Given this list of marker genes Hmgb1, Spn, Ccnd3, Gal, Slc4a2, Abl1, Cd27, Sh2d2a, Cd209d, Tnfrsf14, Nfix, Lep, Il12b, Slfn1, Itgal, Ctps1, Lgals3, F2rl1, Zfp335, Dock8, Ido1, Aif1, Foxj1, Marchf7, Armc5, Itch, Btk, Zp3, Pla2g2f, Cd300a, Lef1, Zc3h12d, Tmem131l, Tnfrsf4, Slc39a10, Cd180, Itgb2, Coro1a, Clec2i, Cd40, Impdh2, Crip3, Phf7, Icosl, Gnrh1, Irf1, Vav3, Sftpd, Havcr2, Cd59a, Cd24a, Il2 (NCBI Gene Id 16183), Cdkn1a, Cd70, Il1a, Vtcn1, H2-DMb1, Cd22, Irs2, Il7r, Bcl2l1, Ceacam1, Ifnar2, Vsig4, Vpreb1b, Enpp3, Ccr2, Ager, Dhps, Plcl2, Nmb, Arg2, Hhex, Tnfsf4, Selenok, Pnp, Tarm1, Crtam, Ocstamp, Ndfip1, Il7, Mif, Pawr, Cd209a (NCBI Gene Id 170786), Flt3l, Itgax, Csf2, Ccdc88b, Cnn2, Kctd9, Pla2g2a, Cd3e, Satb1, Erbb2 (erb-b2 receptor tyrosine kinase 2), Trem2, Ptprc (protein tyrosine phosphatase receptor type C), Il23a, Casp3, Efnb1, Tnfsf13, Hprt1, Rag2, Flt3, Cd59b, Mzb1, Gpam, Cx3cl1, Gsk3b, Znhit1, H2-Aa, Tyrobp, Cd74, Csf2ra, Stat5a, Cd44, Myd88, Lilrb4a, Ikzf3, Kitl, Il12a, Cd320, Pla2g2d, Vcam1, Dlg1, Tnfrsf21, Csf2rb, Prlr, Azi2, Pcyt1a, Fgf10, Cd38, Sos1, Ada, Adk, Traf6, Pth, Ctnnb1, Inpp5d, Cd209e, Fkbp1b, Chrnb2, Sh3rf1, Carmil2, Rc3h2, Syk (spleen tyrosine kinase), Clec4g, Nmbr, Vpreb1a, Il13, Cebpb, Rc3h1, Msn, Gpnmb (NCBI Gene Id 93695), Impdh1, Tyk2, Anxa1, Vsir, Malt1, Ihh, Ticam1, Ptk2, Pycard, Tirap, P2rx7, Tlr9, Tnfsf13b, Il27, Ahr, Npr3, Sdc4, Ifng, Jak2, Slc7a1, Il4i1, Tbk1, Tnfsf11, Tnfrsf13c, Bcl6, Gstp1, H2-DMb2, St6gal1, Pde5a, Wnt4, Rasgrp1, Bid, Clu, Fosl2 (fos-like antigen 2), Cd6, Ephb6, Clcf1, Il3 (NCBI Gene Id 16187), Prkcd, Tnfrsf9, Ripk2, Cd4, Tnfrsf13b, Sash3, Itgam, Il20rb, Nckap1l, Wnt3a (NCBI Gene Id 22416), Cd81, Nfatc2, Sos2, Prnp, Btnl2, Fadd (Fas associated via death domain, NCBI Gene Id 14082), Xcl1, Cd19 (CD19 antigen), Slc4a1 (solute carrier family 4 (anion exchanger), member 1), Lipa, Blm, Btn2a2, Il18, Nck2, Ifnb1, Tcf3, Mapk8ip1, Myc, Alkbh5, Rac2, Bmp4, Tspan32, Ripk3, Tnfsf9, Psmb10, Scrib, Stat5b, Lgals9, Pura, Cd244a, Hspd1, Il2ra, Il5, Elf4, Il6, Lyn, Ighm, Mapk1, Dnaja3, Emp2, Ighd, Tnfsf18, Rps6, Cdkn2a, Csf1r, Cfb, Fkbp1a, Lilrb4b, Il1b, Pkn1, Cd151, Igf2, Bap1, Prdx2, Ccl12, Spta1, Scgb1a1, Cblb, Zbtb7b, H2-M3, Zap70, Cd46, Il4, Bmi1, Cd55, Cd79a, Igf1, Muc19, Cd209c, Cxcl12, Il34, Ccr7, Glmn, Siglecg, Laptm5, Ndp, Fcgr2b, Cd37, Cd274, Nr5a2, Ccl19, Tlr4, Trp53, Shb, Gja1, Btla, Sox11, Ncstn, Bcl2, Prkar1a, Il21, Stat6, Il15, Stat4 (signal transducer and activator of transcription 4), Csf2rb2, Ephb2, Lrrc32, Cd80, Gm36723, Cd55b, Pdcd1lg2, Junb, Rps3, Fyn (Fyn proto-oncogene), Igfbp2, Ripor2, Cd276, Arg1, Twsg1, Gpr183, Mpl, Washc1, Tgfbr2, Cd40lg, Il9r, Jak3, Slc11a1, Hells, Il10 (NCBI Gene Id 16153), Hes1, Gapt, Ptpn6, Gba1, Cd86, Cxcr4, Il9, Grem1, Prkcq, Csf1, Mcemp1, Tnfrsf1b, Tfrc, Bax, H2-T23, Cd1d2, Tcirg1, Atm, Kit, Il6st, Mapk3, Nck1, Dock2, Il33, Cd28, Itgad, Peli1, Epo, Slamf1, Ctla4, Dlg5, Lst1, Atad5, Irgm1, Tsc2, Shh, Cr2, Crp, Pla2g5, Cd1d1, Pten, Tac1, Lmo1, Tgfb1, Slamf6, Rassf5, Rasal3, Ighe, Il12rb1, Tacr1, Mef2c, Ppp3ca, Bst1, Lmbr1l, Nf1, Nfkbiz, Ebi3, Ccl5, Card11, Foxp3 (forkhead box P3), Slfn2, Ptpn22, Zbtb32, Mad1l1 (NCBI Gene Id 17120), here is a description of the gene set: species: Mus musculus Mouse Gene Set: GOBP_LEUKOCYTE_PROLIFERATION The expansion of a leukocyte population by cell division.